The following is a description of a gene set: Genes upregulated in subsets of cells of a given type within various tumors studied in species Homo sapiens Human Gene Set: GAVISH_3CA_METAPROGRAM_EPITHELIAL_INTERFERON_MHC from publication Gavish A, Tyler M, Greenwald AC, Hoefflin R, Simkin D, Tschernichovsky R, Galili Darnell N, Somech E, Barbolin C, Antman T, Kovarsky D, Barrett T, Gonzalez Castro LN, Halder D, Chanoch-Myers R, Laffy J, Mints M, Wider A, Tal R, Spitzer A, Hara T, Raitses-Gurevich M, Stossel C, Golan T, Tirosh A, Suvà ML, Puram SV, Tirosh I (PMID 37258682) In this study, an extensive analysis was conducted to define meta-programs (MPs) capturing intra-tumor heterogeneity across a spectrum of tumor types. The approach utilized non-negative matrix factorization (NMF) to analyze each cell type separately within individual tumor samples. This involved the analysis of malignant cells, macrophages, fibroblasts, endothelial cells, epithelial cells, T-cells, and B-cells. NMF was executed with varying parameter values (K=4, 5, 6, 7, 8, 9), thereby generating 39 programs for each cell type per sample. Each NMF program was summarized by the top genes based on NMF coefficients.\nRobust MPs were then delineated for each cell type using a set of stringent criteria, including recurrence within the same tumor, similarity to programs in other tumors, and non-redundancy within a tumor. Subsequently, these robust NMF programs were clustered (per cell type) based on Jaccard similarity, leading to the identification of MPs associated with each cell type.\nTo enhance the quality of the MPs, a refinement steps were undertaken, involving the removal of MPs suspected of reflecting low-quality data (with an overrepresentation of ribosomal proteins or mitochondrial-encoded genes), single-study inclusion, or similarity to miss-annotated cell types., and this is the list of marker genes: HLA-C, IFITM2, TMSB10, HLA-A, IFITM1, BST2, MYL12A, TMSB4X, FKBP1A, ANXA2, TM4SF1, TIMP3, IGFBP7, RAMP2, IFITM3, ID1, ENG, DUSP1, PLPP3, CAVIN2, MT2A, HLA-DPB1, TSC22D1, IGFBP5, VAMP5, RNASE1, ID3, PLAT, LGALS1, MGP, B2M, HLA-DRB5, NHERF2, CRHBP, CRIP2, EMCN, A2M, GIMAP7 (GTPase, IMAP family member 7), IFI27, HLA-E, GNG11, EPAS1, CD74, RAMP3, SPARC, HLA-DRB1, VIM, HLA-DPA1, HLA-B, HLA-DRA (major histocompatibility complex, class II, DR alpha)